The following is a description of a gene set: Mouse Gene Set: MIR_7053_3P species: Mus musculus from publication Chen Y, Wang X (PMID 31504780) Genes predicted to be targets of miRBase v22 microRNA mmu_miR_7053_3p in miRDB v6.0 with MirTarget v4 prediction scores > 80 (high confidence targets)., and this is the list of marker genes: Hsp90b1, Arap2, Pigk, Atp2a3, Slc4a7, Ppp2r5d, Gabrb3, Cntnap2, Ldlrad3, Fnip1, Saraf, Tyr, Ccdc68, Nlgn1, Cdk14, Atp1b4, Zfp39, Edaradd, Pex13, Cep350, Pex12, Ctdspl2, Cpeb1, Ocln, Cep104, Epb41l1, Phactr3, Calhm5, B020004C17Rik (RIKEN cDNA B020004C17 gene), Ahrr, Zeb2 (NCBI Gene Id 319891), Itgb8, Mtg2, Tbl1x, Paip1, Jade2, Alg6, Map3k13, Chrdl1, Fyco1, Nfix, Spon2, Bmpr1a, Map1b, Atp2c1, Emcn, Cdk4, Ak1, Tmt1a3, Lrp2, Nol4, Prpf40a, Arhgap36, Herc4, Mapk8ip2, Ssbp2, Zdhhc15, Nagpa, Shisa7, Nsun5, Cnnm1, Rimkla, Gria2, Ahsa1, Zfp946, Slc20a1, Dnmt3a